Given this list of marker genes PMS2P5, INO80D, THADA, STAG2, PLEKHG6, ADAM28, LAGE3, TIMELESS, TNFRSF25, ARHGDIB, APBB3, SF3A3, MRPL16, LIME1, CDK5RAP1, ALOX12P2, MCM5, DPP8, ANAPC15, EID1, TM7SF3 (NCBI Gene Id 51768), VTN, STMN1, OXSM, USP7, ADCY8, STIM1, FAM30A, CELSR2, HLA-DRB1, HNRNPH1, BCOR, GUCY1B1, MX1, TUBGCP4, RUNX3, CLK1, TAPBPL, ABHD10, ACAD10, CUL1, BUB1B, XPA, TNFAIP8 (TNF alpha induced protein 8), STX11 (syntaxin 11), PTMA, C1QTNF3, FBXL12, MRPS22 (mitochondrial ribosomal protein S22), CYTH4, ZNF248, DNAJC16, POLG2 (NCBI Gene Id 11232), RASGRP2, DNAH3, PTPRCAP, THAP11, APOA4, MC1R, NMI, PCM1, RAB25, MCM6, PRLH, PLCD1, DAP3, SHANK1, PRUNE1, RNF114, TRAIP, HSD17B7, MGMT, ZNF606, DHX40, PDCD1, CNDP2, HAPLN2, TRAPPC9, GAS7, HIVEP3, TGIF2, PCNA, FH, ENOSF1, SLC46A3, TRANK1, HLA-DMB, MPHOSPH10, PA2G4, SNRNP200, C10orf95, MICU1 (mitochondrial calcium uptake 1), MED9, SALL2 (spalt like transcription factor 2), ENTREP1, TUBD1, DAPK1, BANP, ORC1, SLC37A4, PWP1, THRA, PPP1R8, MAB21L4, NEUROD2, SNN, ABCF1, RNASEH2B, FNDC8, SCN8A, DET1, GRAMD4, ARPP21, SECISBP2, HMCES, CAPN3, DTL, EIF4A1, HABP2, RAP1GAP2, SETDB1, TP53AIP1, POU2F1, GATB, IMPDH2, CYBA, HMGB2, RAB4B, MYCBP2, TUBGCP5, DPYSL4, HADH, AAGAB, PPWD1, CCDC57, KCNK7, BCL11A, THOC1, FBXL14, FGF18, FASTKD1, NUP107, DCLRE1C, ADA2, EDAR, CSF2, PGS1, CCT7, DYNC2I1, SAYSD1 (SAYSVFN motif domain containing 1), ZNF467, C8orf44, QRICH1, ZNF235, RPS8, GRSF1, SLC27A5, NHERF1, KCNMB3, EZH2, ARHGAP32, TBC1D31, COQ8A, HSPBAP1, ICOS, PRDM4, FMNL1, BAG5, MVK, CHAF1A, NUP88, ZXDC, MX2, QRSL1, FANCC, CDK13, GUSBP14, ANAPC5, SGF29, AQP8, TOP1, RFC1, NCK1, RAD54L, ZMYND10, GPD1L, MSH2, ETFB, MRPS35 (NCBI Gene Id 60488), TBP, PPP2R5A, TRAT1, USP24, SOX18, LINC00574, CAT, IDE, STS, here is a description of the gene set: species: Homo sapiens Human Gene Set: GSE1460_INTRATHYMIC_T_PROGENITOR_VS_THYMIC_STROMAL_CELL_UP Subpopulations of human fetal thymocyte and circulating naïve T cells were obtained through FACS sorting, including CD3-CD4+CD8- intrathymic T progenitor cells (ITTP), CD3intCD4+CD8+ \double positive\ thymocytes (DP), CD3highCD4+CD8- \single positive\ thymocytes (SP4), CD3+CD4+CD8-CD45RA+CD62L+ naive T cells from cord blood (CB4+), and CD3+CD4+CD8-CD45RA+CD62L+ naive T cells from adult blood (AB4+). Genes up-regulated in comparison of intrathymic T progenitor cells (ITTP) versus thymic stromal cells. from publication Lee MS, Hanspers K, Barker CS, Korn AP, McCune JM (PMID 15210650)